The following is a description of a gene set: Many cancer-associated genes remain to be identified to clarify the underlying molecular mechanisms of cancer susceptibility and progression. Better understanding is also required of how mutations in cancer genes affect their products in the context of complex cellular networks. Here we have used a network modeling strategy to identify genes potentially associated with higher risk of breast cancer. Starting with four known genes encoding tumor suppressors of breast cancer, we combined gene expression profiling with functional genomic and proteomic (or 'omic') data from various species to generate a network containing genes linked by 866 potential functional associations. This network shows higher connectivity than expected by chance, suggesting that its components function in biologically related pathways. One of the components of the network is HMMR, encoding a centrosome subunit, for which we demonstrate previously unknown functional associations with the breast cancer-associated gene BRCA1. Two case-control studies of incident breast cancer indicate that the HMMR locus is associated with higher risk of breast cancer in humans. Our network modeling strategy should be useful for the discovery of additional cancer-associated genes. from publication Pujana MA, Han JD, Starita LM, Stevens KN, Tewari M, Ahn JS, Rennert G, Moreno V, Kirchhoff T, Gold B, Assmann V, Elshamy WM, Rual JF, Levine D, Rozek LS, Gelman RS, Gunsalus KC, Greenberg RA, Sobhian B, Bertin N, Venkatesan K, Ayivi-Guedehoussou N, Solé X, Hernández P, Lázaro C, Nathanson KL, Weber BL, Cusick ME, Hill DE, Offit K, Livingston DM, Gruber SB, Parvin JD, Vidal M (PMID 17922014) Human Gene Set: PUJANA_ATM_PCC_NETWORK studied in species Homo sapiens Genes constituting the ATM-PCC network of transcripts whose expression positively correlated (Pearson correlation coefficient, PCC >= 0.4) with that of ATM across a compendium of normal tissues., and this is the list of marker genes: PPM1A, INTS10, H3C11, PMS2P3, AFF2, GINS1, EIF3M, RBM8A, TRAF3IP3, UBE2D3, ILF2, NECTIN1, TRIM31, MRPS31, PSD4, PNO1, FCHO1, TAF1, B2M, TAF2, GRK2 (G protein-coupled receptor kinase 2), UBE2S, UBFD1, NFATC1, PRPF19, CUX1, RPL10A, CASP8, GTF2B, THOC2, LINC02172, MAP3K1, PFKFB4, IFNG, MAPK8 (NCBI Gene Id 5599), IL4, RBM6, UBA3, B3GAT2, NT5C2, PDAP1, CD96, SNX15, PRPF40A, PCBP1, SIM2, GALNT2, MYBPH, CTAG2, UBE2J1, KCNMA1, JARID2, RASSF8, NBN, APOBEC1, KHDRBS1, PLCG2, FLT1, RPL21 (ribosomal protein L21), LILRA3, LRRFIP1, TCL1A, DRD1, ERC2-IT1, PFAS, PPIA (peptidylprolyl isomerase A), RPL23A, BTK, CD72, PRPSAP2, TCF3, PHF3, STK17B, EIF4EBP2, GTF2E1, DNA2, MYBL2, GPR18, PSMC3IP, IMMT, SERTAD2, XRCC2, IFI16, KCNA5, ITGBL1, CLK2, CDV3, PIGB, HMGB1P8 (high mobility group box 1 pseudogene 8), ZZZ3, SKAP1-AS2, MTERF1, CLASRP, ZNF318, PAPOLA, ERCC5, GTSE1, HTR4, KCTD20, GRP, CENPI, SFPQ, OPCML, RPL14, TFF2, CPT1A, CHST7, ZFYVE26, TOP1, PRDX3, CCNF, FTSJ1, H2AZ2, MTHFD2, PLCB4 (phospholipase C beta 4), C6orf62, LDHB, CSF3, PTPN1, UBR2, PDCD10, BPTF, RBBP8, MBD2, DUT, ICE1, CD1A, CDC123, PPM1D, EIF3F, CASP3, NGDN (NCBI Gene Id 338007), PCNA, PRPS1, APOBEC3C, KHDRBS2, NOP56, DKC1, DCAF7, SFT2D2, ATF2, NONO, TREX2, TMSB4Y, KDM4A, DEPDC5, HK2, RAN, EDEM1, EYA4, PTPN2, UBE2E1, CD37, PIK3CG, SIT1, LBR, CRYAA, STAG2 (STAG2 cohesin complex component), SRRM1, MKI67, NPHP1, CBFA2T3, IGHV5-78, MAGOH, EIF3E, EIF5AL1, HMGN1, NUP62, KCNA1 (potassium voltage-gated channel subfamily A member 1), SUZ12, RNASEH2B, COL21A1, ZNF345, GDI2, RB1CC1, FOXM1, TIAL1, KCNB1, ITPK1, CLPX, GNAQ (NCBI Gene Id 2776), INSIG2 (NCBI Gene Id 51141), DARS1, GCGR, ARHGAP35, TM9SF4, DNAJC2, PGAP2, RPS12, NAE1, EED, DDX27, SLC12A4, FCGR2A, PDK1, NUP214, TECPR2, BTN3A1, RASSF2, LINC00342, ATP5MC2, GSS, FLI1, CDC20, ARHGEF6, SPAST, RAD21, KHNYN, DNAJC13, LARP4B, MYBPC2, COX7B, CEP135, SMCHD1, ZNF24, RGS13, HOXC11, HDAC6, TP53, RPA3, MASP2, NUTF2, PRMT2, MRPS14, ACOT11, STK10, MSH5, TTTY1, TTF2 (NCBI Gene Id 8458), IFNAR2, LY75, RAD51AP1, CADM3-AS1, CD79B, POLR3G, PLIN3, SIRPB1, SLC1A4, CNOT3, UPF2, CORO1A, ZNHIT3, GHRH, PCF11, SCYL3, HNRNPK, SMG7, SP100, ABCE1, SAP25, PAXIP1, DDX39A, SRSF9, BLNK (NCBI Gene Id 29760), UVRAG, PPP2R1B, DDX10, BNIP2, TFAM, PRMT3, CNOT1, NEK9, ERH, HNF1B (NCBI Gene Id 6928), CD1C, HIRA, UGT2A1, PARN, CNPY3, SPTLC2, ZBTB24, ETV6, USP10, NEMP1, DMAC2L, ROBO1, MSH2, CEBPZ, ECE2, TCERG1, YIPF4, LAMB4, KCNH1, YAF2, RAD54L, PSMA5, NRAS, NPM3, B3GNTL1, ITGA2B, INPP5E, BMS1, IL5RA, ARPC2, SNRPA, CHUK, CHKB, GRAP (NCBI Gene Id 112268188), GPR65, USP4, PTMA, TAF11 (TATA-box binding protein associated factor 11), ZC3H4, CHAF1B, GLIPR1, ACTR2, ZNF157, SMARCB1, ICAM3, EWSR1 (EWS RNA binding protein 1), GTF2H2, AMMECR1, RPS15A, NPM1, LDHA, INE1, OXA1L, ABO, EXOSC10, TGDS, CIAPIN1, CNOT8, STX10, NAT1, PSME1, SEMA4F (NCBI Gene Id 9408), ANAPC10, RCOR1, ARHGAP25, S100A2, CNOT9, ING3, SCAMP5, DLST, P2RY10, FAS, RASGRP2, KLHL23, UBXN7, GLRA3, ZCCHC14 (zinc finger CCHC-type containing 14), SASH3, GTF2H4, TLR6, NCBP2, PMM2, CCT8, ZNF169, SHH, CBFB, CR1, EIF5B, DHX16, NOP2, GPR3, DLEU1, ZNF337, POLR2B, PAK2 (p21 (RAC1) activated kinase 2), SEMA3D, RPS20, VPS4B, TSNAX, TGIF2, RIOK3, CREG1, PLAGL2, IRF2, ABCC1, MPHOSPH9, TACR3, LINC00588, ILF3, MAP4K1, POP4, RGS10, MAX, TRIM22, RALGAPB, BBS9, CD99P1, RBM3, CEP68, EIF2S3, WIZ, PPP2R5C, PFKFB2, SNW1, PFDN6, THRA, DHX9, BAZ1B (NCBI Gene Id 9031), GNAO1, GMFG, LINC00667, ESR2, CDKL1, CASP5, RPL4, GUSBP3, TFEC, CNTN6, HNRNPL, UTP3, ADCY7, POU6F1, FMNL1, MFN1, RRP1B, MRPL3, SNRPA1, SCFD1, CSF2RA, M6PR, SLC2A1, HLA-DRA, IL7, OARD1, TAF4B, TAOK3, CD48, BET1, PRKY, MDM1, LSM6, NRP2, GRB2, SREK1IP1, AIM2, DDX39B, AHSA1, PRDM2 (PR/SET domain 2), PFKFB3, IFNW1, AFDN-DT, POLG, PABPC1, TGOLN2, TRA2B, SLC24A1, PCGF1 (NCBI Gene Id 84759), TCF20, SRSF6, CUL2, SP2, RFC3, DLD, MS4A1, ZC3HAV1, SP110, PELP1, NCAPD2, PHACTR1, ARPC5, NPAS1, EXOSC2, CNBP, CDC14A, ABL1, OGG1, CUL4A, KIF25-AS1, PLEK, RPS4X, ABCC10, PCDHB17P, ABCB7, PDS5A, NCBP1, HNRNPA2B1, CD3G, ZNF266, CCR2, ITGA4, FABP5, SCAF11, CASP7, MDFI, RPL23, ZNF37A (NCBI Gene Id 7587), RBMS2, PRKCD, TNFAIP8, SMC3, RGS6, TOPBP1, MYH3, CUL9, TBX6, DOCK2, H4C2, IL24, MSL3, RNF44, KNTC1, EZH2, THAP12, TFAP4, SNRPB, TBP, GNAT1, NPRL2, PHIP, PPP1CC, KCNE1, SF3B1, MYCBP, RPL37 (ribosomal protein L37), IKBKG, MC5R, CCNG2, BTF3, UBE2C, SPI1 (Spi-1 proto-oncogene), RSL1D1, RPL30, LRIT1, GEMIN2, CA7, BUB3, RPL27, CTR9, MYL1, TOP2B, RAP1B, PRKDC, KCNC4-DT, NDC80, MYC, MARCHF3, RPS27A, CAPZA1, ITGAD, MAGEA9, PSMA4, LTA4H, POU5F1, TDG, KCTD7, RPS3A, KLRA1P, GLE1, NBEAL2, RECQL, GTF3A, HCLS1, SRSF1, LTA, RPIA, HNRNPA1, TGFB1, DPM1, PSMD3, BLM, LY86, TGM5, SYK, SLBP, TMEM131L, ROCK1, RIPOR2, RPS23, YME1L1, RPA2, SSB, COPS3, KLF12, RPS27, IFI44, CCT4, ANKRD26, NLRP3, WDR43, GPSM3, LPAR4, TOP2A, TIMELESS, LAMC2, IFT20, MED20, SSBP2, NCOA6 (nuclear receptor coactivator 6), ALOX12, USP1, POLR3C, ATIC, FUBP1, CD22, INPP5D, ADNP, HTRA2, DAP3, REL, FCHSD2, PSMB8, OAS1, EP300, P2RX7, TTBK2, ALOX5 (NCBI Gene Id 240), RECK, ARFGEF2, TCOF1, FNBP4, ARIH2, GNA13, RPL31, HTR1E, TFCP2, RAB3GAP2, GSR, COMP, NXPH2, SLC15A1, NUP50, ADSL, APBA1, NMB, GIP, TRA2A, FAM76A, NBR1, MCM4, CNGA3, PNMT, XPO1, LPGAT1, EIF1AY, AVPR1B, ICOSLG, YTHDC1, POLR3F, IFT25, PART1, IDH3B, TXNL4A, ODC1, AURKA, OBSCN, VAMP1, CASP2, STX16, ANXA13, ELAC2, KYNU, ZBTB6, TGFBR1, ZNF43, SNORA11F, AGGF1, N4BP2L1, ACKR2, LY9, TRAV9-2, SLC14A2, ESPL1, PTPN18, SMN1, TARBP1, SLC25A14, BAZ1A, PRPF18, PABPN1, CHERP, EEF1B2, POU4F1, POLE3, MICB, HNRNPH1, PKN1, RUVBL1, CLDN9, GRIA1, NOS2, PHOX2B, KIF21B, CSNK1G2, CCL3 (C-C motif chemokine ligand 3), IGBP1, TXK, PRPF31, CORT, MTF2, CRLF3, CD47, CD300C, DLGAP2, HLA-DOA, CYP1A1, GCH1, MAT2A, NOP14, ITPKC, ACADM, LILRB4, MTDH, FGF18, POU2AF1, PTPN7, PAX4, RPS7, HNF4G (hepatocyte nuclear factor 4 gamma), SH2D1A, FANCI, SUMO1, GPN1, SUPV3L1, MTCP1, STMN1, IK, ABI1, PPP2R5E, RPL36AL, HMGB2, METAP2, FCER2, DAPK2, BID, U2AF1 (NCBI Gene Id 7309), CD1D (NCBI Gene Id 912), CNTRL, TCEA1, ATG12, IFFO1, USP19, KDM3A, KRT32, IL10RA, OGT, RIMS1, TMEM262, CSF2RB, NUP153, ATP11B, YWHAB, MR1 (major histocompatibility complex, class I-related), ZKSCAN4, PARP3, MRPL33, RPA1, APC, CNKSR2, CRHR1, YY1, MAK16, ZWINT, ZNF134, AP1G2, TSPY2 (NCBI Gene Id 96302), RCC1, HSPA9, SRP72 (NCBI Gene Id 6731), NMI, KHDC4, MBD4, TOMM40, PCYT1A, CHAF1A, HSPA8, NPIPB15, LIAS, ATXN3, GYPE, RSU1, HOXD10, GTF2A1 (general transcription factor IIA subunit 1), EIF4H, LCP1, ELOVL5, IRAK1, NR3C1, CD52, CDH8, GOSR1, ASF1A, MAD2L1, OR2F1, ISG20L2, DYRK2, WTAP, BAX, TKT, CCL11, ADAM22, ZNF131, IGLL1, SERBP1, LPXN, CCNE1, MTMR1, PAX3, RFC1, ST20, EEF1A1, DIDO1 (NCBI Gene Id 85362), UTP18 (NCBI Gene Id 51096), SP140, SNRPE (NCBI Gene Id 6635), GPX7, FCGR2B, KXD1, SLC7A6, ZNF330, BTF3P11, POLE (DNA polymerase epsilon, catalytic subunit), ERCC3, PDX1, SHMT2, KRT31, GPD2, ZNF273, AP3S1, ARHGDIB, CHEK2, HLA-DPA1, NBR2, CRCP, RAD51C, IDS, PNN, GPR171, RPL17, RNASEH1, HNRNPR, EPB41, DPH2, SSBP1 (single stranded DNA binding protein 1), DUSP11, NOP16, ZNF354A, PITPNA (phosphatidylinositol transfer protein alpha), NUP210, DEK, CAD, SEC23IP (NCBI Gene Id 11196), ITFG2, LINC03000, OSBPL3, MCM2, SNX2, CHRND, HIPK3 (homeodomain interacting protein kinase 3), CENPA, SAFB, HNRNPC, NPHP4, RSRP1, ZNF804A, SLC7A1, H1-4, BTAF1, MRE11, ADAM19, STXBP3, LSM14A, DDX21, KIFC1, CDK11B, GPR161, CTSS, RAD9A, SCNN1B, TPP2, BAZ2A, TP53I11, GPLD1, EIF4B, EMG1 (NCBI Gene Id 619532), CIITA (class II major histocompatibility complex transactivator), RRP7A, CAST, ENOX2, OAS2, ENSG00000240291, IPO9, AOC2, RFX5, SRSF2, RPL6, POT1, SAP30, SP3, CCL23, FAM53B, ARHGEF1, PIM2, FASLG, PDE6D, ARNT (NCBI Gene Id 405), KDM3B, NR2C2, FSCN2, RPL36A, PKM, ST3GAL2, RCN2, POLR3D, NCK1, BLMH, NKTR, SET, SRSF3, STK38, HDAC1, OLFML2B, MAN1A2, TAP1, RIF1, PROP1, CIR1, HNRNPH2, GP1BA, PSME2, TULP3, PTP4A2, UBE2G1, RANBP1, DKK3, XPC, DGUOK, CSNK2A1, IGKC, HEXIM2-AS1, SCN2B, EP400, RREB1, NCF4, INHBA, STK4, PPP3CC, H2AZ1, PGK1, LYN, KIAA0930 (KIAA0930), CD79A, VAV1, RASSF1, ANGEL1, RPS25, RFC4, WNT11, CLTB, CXCR4, SNX4, DDX28, CEP57, MED1, HNRNPF, RPL19, MMP20, GNL2, FGF6, DDX46, UBN1 (NCBI Gene Id 50641), PTEN, MYO1A, NACA, H4C13, ZNF510, CLCN7, ATP11A, CDK1, ARFIP1, POP5, EN2, RNF139, DR1, BORCS8-MEF2B, GRK6, CDKN2C, FRG1, CDY1 (chromodomain Y-linked 1), ICOS, RSAD2, SF1, NFYB, CFLAR, USP34, RRS1, ITGB1BP1, MACROH2A1, GNB3, SLC16A5, SELENOF, SNRNP27, IKBKE, IL16, APEX1, FUS, LILRA1, OFD1, TBCA, RWDD3, GPR37L1, HCP5, IDO1, CUL5, ACYP1, SMC1A, SLC19A1, RABEP1 (rabaptin, RAB GTPase binding effector protein 1), NUFIP1, DNAJC7, UCP2, DNMT1, RRM1, CAMK4, TMPO, E2F5, METAP1, NSMAF, CEACAM4, KLHL18, WAS, STAT1, RALBP1, AMIGO2, BCAT1, RAF1, NFIA, TMX1, HAT1, BCL6, RUNX1, TTTY2, CDK13, ATP5F1A, SFI1, CBFA2T2, CYP2C18, ARHGEF18, IFIT3, RAP1A, SNAP23, IL15, RPL7, VHL, LAPTM5, LSS, PDS5B, TBC1D5, PLCL2, YBX1, CD53, MATR3, POU1F1, MCM5, WASHC5, SMAD2, KATNA1, MSH6, GRIP2, GARRE1, HSPA4, NFATC2IP, PITPNB, ATP5PB, PCDHA12, ELAVL1, CD247, RGS19, PLCG1, CCHCR1, MARCHF7, G3BP1, RB1, HTR3A, RNGTT, ZNF117, KYAT3, CDC7, ONECUT1, TMEM243, RPL11 (ribosomal protein L11), SMC5, CBX3, ZNF141, LAIR1, MC2R, SLC25A16, RASA3, TMEM123, DNAJC24, CTCF, BCL7A, AMPD3, STRN, OXSR1, TRIM32, PWP2, RPL5, ZNF862, LIF, ITGB7, TNK1, URB2, UPK1A, PTTG2, DNTTIP2, GJB5, BRME1, PARP1, TTC39A, PTPN6, EXOSC8, UNG, PRP4K, RAD51D (NCBI Gene Id 5892), ANP32E, NCL, PKD2, SIX6, PRPF4, PPP1R2, GCFC2, LPAR2, RAC2, SNRPF, HEXA, MVK, DOCK10, E2F4, SIKE1, IRF8, MED6, ATM, ACTR3, DSCR4, CAP1, CENPC, SPAG11B, ZNF253, CD36, HPS1, ETS1, PRRC2C, INPP4A, CLP1, PPWD1, MBNL1, RBMX, AKAP17A, TAF5L, OSTF1, UBA2, CD38, PAICS, JAK2, DDX5, RBBP7, KPNA6, ATP5MJ (NCBI Gene Id 9556), BCL2L11, DOLPP1, STX2, DCK, CASP10 (caspase 10), FGF4, MCC, FLT3, H3P37, SMNDC1, ITK, PLK4, POU2F2, RASGRP1, PTOV1-AS2, TNKS, NOLC1, DHFR, KRT20, OR2H1, HMMR, FAM216A, EIF4A3, PLXDC1, PIGC, NSD2, ORC5, ALKBH1, STAT5A, ADRA1D (NCBI Gene Id 149), NUDT1, IKBKB, ME2, RPL22, NFX1, C1QBP, MAPT, MDM2, ZNF101, RHOH, MYF6 (myogenic factor 6), SMARCA5, MLANA, PCLAF, NSA2, MX2, CSK, EIF3H, RPLP2 (ribosomal protein lateral stalk subunit P2), GRIK1, POLA1, H2AC17, HMGN3, SMARCD2 (NCBI Gene Id 6603), SLC16A6, PPIL6, LAIR2, TSFM, CD40, THAP9-AS1, NCKAP1L (NCBI Gene Id 3071), PEX13, KIF20B, PAFAH1B3, IRF5, GTF2F2, AURKB, RFTN1, RPS24, POLD4, OPRL1, RANBP9, SENP5, TLL1, SMC4, ZNF780A, TFDP2, ECD, TANK, CCNA2 (cyclin A2), ELF1, DDX52, SMARCD1, SMC2, TBX5, ERCC2, SNRPB2, ANP32A, RNF126, KRT83, ADAM17, NHP2, DNAJC9, MFAP3, NFATC3, RRP8, NEK7, HNRNPAB, PARP2, RAB30, DDX18, HNRNPA3, PSIP1, RPS6KB1, ZNF267, RPL13A (ribosomal protein L13a), ELK3, MOB1A, GTF2H3, ZNF8, URB1 (URB1 ribosome biogenesis homolog), TAF5, MS4A2, CLINT1, NFKB1, ABHD3, SLC7A11 (solute carrier family 7 member 11), RNF114, RPS19, TFDP1, KCNA6, PHTF2, DIMT1, ADAM10, SETD1A (NCBI Gene Id 9739), CHMP7, HNF1A, INTS1, GATAD1, TOE1, TIAM1, HTR7, ABCF2, POM121 (POM121 transmembrane nucleoporin), ARPC3 (NCBI Gene Id 10094), GJA8, ADAR, MYH15, AP3B1, LYPLA1, GIT2, CCKBR, SF3B4, NAP1L1, SGPL1, FBXL4 (NCBI Gene Id 26235), NR2C1, ALOX5AP, IRAG2, PAX2, AURKC, ALX1, CPSF4, TEC, XPNPEP1, PIBF1, IRF4, RMND5A (NCBI Gene Id 64795), KLRC4, IL2RG, LSM1, BRCA1 (BRCA1 DNA repair associated), CCNT2, POM121L14P, HNRNPM, ARPC1B, SRSF11 (serine and arginine rich splicing factor 11), ALPK3, LMNB1, RBBP4, IL27RA, CREBZF, FBLN1, FGF8, GATA6, PIAS2 (NCBI Gene Id 9063), MTF1, FAM120A, TNFRSF10D, ZNF516, PSMD9, HMGN4, CELF1, DIAPH1 (diaphanous related formin 1), SLC6A6, PTPRC, VRK1, HMGN2, BFSP1, IL13RA1, COL10A1, ARHGAP11A, SLC25A46, ZHX2, TBCC, MTA1, AJAP1, LARP7, TNF, PPIG, DCP2, RSC1A1, TELO2, OIP5, NASP, ARHGAP4, RPL34, GRAMD4, KRT2 (keratin 2), HTR2A, MCM6, ANP32B, TAB1 (TGF-beta activated kinase 1 (MAP3K7) binding protein 1), SYNCRIP, CD19, EXOG, PIK3CD, PPP6R1, TNFRSF17, CNIH1 (NCBI Gene Id 10175), ZNF33B, RPS6, EIF2B5, FBL (fibrillarin), ZBTB33, ZNF22, CMKLR2, UBAP2L, PPIP5K2, IL10RB, ZNF160, RBBP6, SRSF8, NSL1 (NSL1 component of MIS12 kinetochore complex), NPAT, BRD1, DDX3X, SRSF10, AATF, NKRF, IKZF1, ACAP2